The following is a description of a gene set: Any process that modulates the frequency, rate or extent of neuron maturation, the process leading to the attainment of the full functional capacity of a neuron. This process is independent of morphogenetic change. species: Homo sapiens Human Gene Set: GOBP_REGULATION_OF_NEURON_MATURATION, and this is the list of marker genes: BCL11A, EDNRB, MAP3K13, TBX6, RAC1, BCL2, LRRK2, RAC3, NGF